The following is a description of a gene set: studied in species Homo sapiens Human Gene Set: GOCC_PROTEIN_COMPLEX_INVOLVED_IN_CELL_ADHESION Any protein complex that is capable of carrying out some part of the process of cell adhesion to the cell matrix or to another cell., and this is the list of marker genes: LAMA2, LGALS2, TSPAN32, LAMB2, ITGAE, ITGA11, LAMC1, VTN, ITGB7, TNC, ITGA3, ITGB3, EMILIN1, ITGA9, ITGA4 (NCBI Gene Id 3676), MMRN2, ITGB4, EMILIN2, CD28, ITGA1, ITGA2B, LYN, IZUMO1, TNXB, LAMA1, ITGBL1, ITGB6, CTLA4, ITGB2, ITGAL, GLIPR1L1, ITGB5, NLGN1, ITGAD, LGALS1, ITGB1, ITGAX, NRXN1, JAM2, PLAUR, ITGA7, ITGA5, ITGA2, PLAU, JAM3, ITGAV, ITGA6 (integrin subunit alpha 6), NID1, CD80, ITGB8, ITGAM, TNR, TNN, ITGA8, LAMB1, ITGA10, MMRN1